Given this list of marker genes GABRG2, ADAR, SCN2A, RRM2B, GCH1, MT-ATP6, SLC25A4, GABRA1, SCN9A, TMEM240, PRKN, TWNK, SCN1B, ATP6AP2, PTRHD1, POLG, FRRS1L, RAB39B, DAB1, CP, SLC6A3 (solute carrier family 6 member 3), NUP54, PCDH19, TK2, NUP62, KCND3, SCN1A, KCNN2, SLC19A3, KCNA4, MME, POLG2, here is a description of the gene set: Human Gene Set: HP_COGWHEEL_RIGIDITY species: Homo sapiens A type of rigidity in which a muscle responds with cogwheellike jerks to the use of constant force in bending the limb (i.e., it gives way in little, repeated jerks when the muscle is passively stretched). Cogwheel rigidity